Given this list of marker genes AAAS, NUP188, AP2S1 (adaptor related protein complex 2 subunit sigma 1), tat, PSMD2, vpr, PSMB4, NUP107, POM121C, ARF1, CD8B, SEM1, SEC13, NUP205, PSMB2, NDC1, PSMC5, NUP58, HMGA1, RANBP1, NUP85, PSMD3, PSMC1, DOCK2, B2M, RANGAP1, PSMB5, NUP42, NUP160, NPM1, nef, ELOB, PAK2, RANBP2, PSMD1, SEH1L, AP1B1, CD4, PSMB3, CCNT1, AP1M1, vpu, RCC1, ADRM1, CUL5, PSMB1, PACS1, HCK, RBX1, TPR, ATP6V1H, CD28, SLC25A5, NUP98, PSMD11, NUP214, AP2M1, BTRC, PSMA7, SLC25A4, NUP133, PSMB6, UBC, NUP155, vif, PSMA5, UBA52, NUP210, NUP43, PSMD12, AP1M2, PSMC2, BANF1, RPS27A, AP2B1, AP2A1, SLC25A6, CDK9, SKP1, UBB, PPIA, NUP93, NUP62, AP1S2, PSMC4, NUP54, PSMD8, KPNA1, ELMO1, AP1S3, PSMA6, PSMB7, AP2A2, XPO1, gag-pol, PSMC3, PSMA1, ELOC, NUP50, NUP88, rev, PSMC6, RAE1, PSIP1, PSMD13, PSMD6, PSMA2, LCK, RAN, CD247, PSMA3, FYN, PSMD7, AP1G1, NUP37, PSMD14, gag, HLA-A, POM121 (NCBI Gene Id 9883), APOBEC3G, KPNB1 (karyopherin subunit beta 1), NUP153, PSMA4, AP1S1, NUP35 (NCBI Gene Id 129401), RAC1, here is a description of the gene set: Reactome Pathway: Host Interactions of HIV factors part of: HIV Infection species: Homo sapiens Like all viruses, HIV-1 must co-opt the host cell macromolecular transport and processing machinery. HIV-1 Vpr and Rev proteins play key roles in this co-optation. Efficient HIV-1 replication likewise requires evasion of APOBEC3G-mediated mutagenesis of reverse transcripts, a process mediated by the viral Vif protein.